Given this list of marker genes SNCA, RPS26P11, SLC4A1, MBNL3, DCAF12, SLC25A37, GYPA (NCBI Gene Id 2993), ALAS2, FAM210B, RPS26, STRADB, here is a description of the gene set: species: Homo sapiens Individuals fail to elicit protective antibody after hepatitis B vaccination remain at risk for hepatitis B virus infection. Analysis of the transcriptome of peripheral blood mononuclear cells (PBMCs) is essential to elucidate the characteristics of gene expression in non-responders. In this study, we enrolled seven responders who had received three injections and seven non-responders who had six injections of hepatitis B vaccine before. All the participants were then vaccinated with a three-dose boost regimen. Microarray analysis and Luminex assay were applied to examine mRNA expression and Th1/Th2/Th9/Th17/Th22/Treg cytokine and chemokine profiles in non-responders and responders. Differentially expressed genes in PBMCs of non-responders at 5 time points, i.e. pre-vaccination, 3<sup>rd</sup>, 7<sup>th</sup>, 28<sup>th</sup> day post the first dose vaccination and 7<sup>th</sup> day post the second dose vaccination indicated a dense network trend. Compared with responders, nine coding genes (BPI, DEFA1B, DEFA4, CEACAM8, MMP8, FOLR3, LTF, TCN1 and TKTL1) were significantly up-regulated in non-responders at all 5 time points, which could probably be the characteristic genes in hepatitis B vaccine non-responsiveness. Gene ontology analysis revealed that most of the DEGs were related with immune responses. Validation results of these genes using quantitative real-time polymerase chain reaction were mostly consistent with the results of microarray. Cytokine analysis demonstrated that IL-27 and CXCL12 concentrations in responders were significantly higher than non-responders on the 3<sup>rd</sup> day after the first dose and 7<sup>th</sup> day after the second dose of vaccination, respectively. No significant difference was observed in other cytokine and chemokine signatures between the two groups. In conclusion, our results revealed characteristic transcriptome and cytokine changes in hepatitis B vaccine non-responders after boost immunization. Genes down-regulated in peripheral blood mononuclear cell non-responders vs responders in adults (<50) after exposure to Heptatitis B surface antigen vaccine (HBsAg), time point 28D Human Gene Set: QIU_PBMC_HEPTATITIS_B_SURFACE_ANTIGEN_AGE_UNDER50_NON_RESPONDERS_VS_RESPONDERS_28DY_DN from publication Qiu S, He P, Fang X, Tong H, Lv J, Liu J, Zhang L, Zhai X, Wang L, Hu Z, Yu Y (PMID 29580160)